The following is a description of a gene set: Human Gene Set: GSE22601_IMMATURE_CD4_SINGLE_POSITIVE_VS_CD8_SINGLE_POSITIVE_THYMOCYTE_UP from publication Dik WA, Pike-Overzet K, Weerkamp F, de Ridder D, de Haas EF, Baert MR, van der Spek P, Koster EE, Reinders MJ, van Dongen JJ, Langerak AW, Staal FJ (PMID 15928199) T cells develop from progenitors that migrate from the bone marrow into the thymus. Thymocytes are subdivided roughly as being double negative (DN), double positive (DP), or single positive (SP), based on the expression of the CD4 and CD8 coreceptors. The DN stage is heterogeneous and can be subdivided into four distinct subsets in mice based on the expression of CD44 and CD25. In human, three distinct DN stages can be recognized: a CD34+CD38−CD1a− stage that represents the most immature thymic subset and the consecutive CD34+CD38+CD1a− and CD34+CD38+CD1a+ stages. Human DN thymocytes mature via an immature single positive (ISP CD4+) and a DP stage into CD4+ or CD8+ SP T cells that express functional T cell receptors (TCR) and that exit the thymus. In this study, gene expression was measured in each of these nine stages. studied in species Homo sapiens Genes up-regulated in single positive cells: immature CD4 versus CD8 thymocytes., and this is the list of marker genes: SPICE1, TMIE, IL12RB1, MAP7D1, B3GNT2, FAM117B, CBX2, HEMGN, NCK1, HS3ST3B1, FILIP1L, CCM2, RGS2, MYB (NCBI Gene Id 4602), ITPKB, MEN1, MSRB1, NPRL2, HJURP, RPS6KA1, NAB2, CXCR3, SNRK, SASH3, DNAJB4, LRRC8A, SLA, GFI1, DEPDC1B, SLC5A3, MRPS6, IRF2BP2, SLA2, TRAF3IP3, IL16, BTG2, JADE2, CNPY4, CITED2, GRAP, DIPK1A, RHOH, PRKD2, GATA3, NATD1, PTGIR, PADI2, RASSF2, LDLRAP1, PIK3IP1, KCNN4, WDR12, HERPUD1, PAGR1, CDC42EP3, TNFSF11, MTHFR, ID3, MMD, KLF2, MADD, GLRX, HVCN1, ALS2CL, UGCG, CRLF3, MID1IP1, ZNF654, ST8SIA4, TSPAN14, PPDPF, RNF125, DEDD2, TENT5A, SAMTOR, NFATC3, STK26, HAUS3, DUSP10, IRF6, TNFAIP8L1, C8orf58, SLC2A3, RBM38, TNFAIP8L2, TOB1, CNP, DGUOK, SESN2, GTF2I, TSC22D4, TMEM154, TSPAN32, PDE4B, STARD5, FAM53B, RANBP10, IFNAR1, GBA2, SIT1, EVI2B, MXD4, TRPV2, MSL1, TBC1D10B, TBXA2R, GPR68, RFX1, PARP11, ZNF260, FAM78A, DIPK2A, ERF, CCNF, ATOSB, TXNIP, EIF2AK3, PTGR3, RBM4B, GALNT9, ANKRD50, EIF4A2, TBC1D10C, TDRP, FAM111A, CEP57L1, TTK, IRF2, HSDL1, FBXO25, TP53I13, RGS14, RNF181, PTPN22, PHLDA1, RAB19, METRNL, CXCR4, TSC22D3, CD27 (CD27 molecule), TRAF5, GIMAP6, TRAF3IP2, RGS3, N4BP2L1, CREB1, RHOB (NCBI Gene Id 388), CD5, FAAH (NCBI Gene Id 2166), CARD6, PSD4, OTULINL, SNX20, KIF21B, CYTH4, RHOF, SOX4, DOK2, PTGER2, SH2D3C, CDKN1B, ZYG11B, ARRDC3, EHD3, SAP30, FAM89B, GPR132, RASGRP2, JDP2, ZNF467, FRMD8, TNIP1, SELENOP (selenoprotein P), UBE2T, LTB (NCBI Gene Id 4050), SUPT4H1, XYLT2, ACP5, SLC43A2, DDIT4, CBX4, SESN1, LPAR6, MBP, SH2D2A (NCBI Gene Id 9047), INTS6, EVI2A, TTLL1, PRMT2, NIPAL1, MDC1, AMMECR1L, TNFAIP3, DUSP2, RFX5, FAM117A, NOD1, ANGPTL4, GIMAP7 (GTPase, IMAP family member 7), PNRC1